The following is a description of a gene set: from publication Bedogni F, Hevner RF (PMID 34321999) species: Mus musculus Genes selectively expressed by cells committed to projection neuron differentiation beginning in the subventricular zone, in most cases extending into the intermediate zone and cortical plate of embryonic day 14.5 mouse cortex. Mouse Gene Set: HEVNER_SUBVENTRICULAR_ZONE_AND_UP_PROJECTION_NEURON_FATE_COMMITTED_CELLS, and this is the list of marker genes: Stard3, Bcl6, Ntrk3, Nhlh2, Rapgef1, Celsr2, Nhsl1, Fam107b, Mpped1, Mycl, Syn2, Serpini1, Satb2, Scn3a